Given this list of marker genes Pid1, Ucp2, Klf2, Pmaip1, Hspa1a, Zfp36l1, Nr4a1, Fos, Btg2, Cytip, H1f2, Zfp36l2, Klf3, Ubc, Trim35, Uba52, Cox7a2l, Ier2, Neat1, Tsc22d3, Nr4a2, Dusp1, Zfp36, Klf4, Lpar6, Klhl6 (NCBI Gene Id 239743), Fnbp1, Eef2, Btg1, Adrb2, Lyz2, Sgk1, Kctd12, Rab7b, Rgs2, Fosb, Tm6sf1, Jun, Tspan13, Ifngr1, Ier5, here is a description of the gene set: studied in species Mus musculus Mouse Gene Set: CUI_CDC1_TL1A_RESPONSE_DN Cytokines mediate cell-cell communication in the immune system and represent important therapeutic targets. A myriad of studies have highlighted their central role in immune function, yet we lack a global view of the cellular responses of each immune cell type to each cytokine. To address this gap, the authors created the Immune Dictionary, a compendium of single-cell transcriptomic profiles of more than 17 immune cell types in response to each of 86 cytokines (>1,400 cytokine-cell type combinations) in mouse lymph nodes in vivo. A cytokine-centric view of the dictionary revealed that most cytokines induce highly cell-type-specific responses. For example, the inflammatory cytokine interleukin-1β induces distinct gene programmes in almost every cell type. A cell-type-centric view of the dictionary identified more than 66 cytokine-driven cellular polarization states across immune cell types, including previously uncharacterized states such as an interleukin-18-induced polyfunctional natural killer cell state. from publication Cui A, Huang T, Li S, Ma A, Pérez JL, Sander C, Keskin DB, Wu CJ, Fraenkel E, Hacohen N (PMID 38057668) Genes negatively differentially expressed in cell type: cDC1 (conventional dendritic cell type 1) upon treatment with cytokine: TL1A in mouse lymph nodes in vivo.